The following is a description of a gene set: Mouse Gene Set: GOBP_VENTRICULAR_CARDIAC_MUSCLE_CELL_DEVELOPMENT species: Mus musculus The process whose specific outcome is the progression of a ventricular cardiac muscle cell over time, from its formation to the mature state. Cardiac muscle cells are striated muscle cells that are responsible for heart contraction. The ventricle is the part of the heart that pumps blood out of the organ., and this is the list of marker genes: Atg5, Fhl2 (four and a half LIM domains 2), Nkx2-6, Hey2, Nkx2-5, Cdk1, Pitx2, Myh10, Bmp10, Prox1, Mef2a (myocyte enhancer factor 2A), Lmna